The following is a description of a gene set: studied in species Homo sapiens Human Gene Set: GOCC_LATE_ENDOSOME A prelysosomal endocytic organelle differentiated from early endosomes by lower lumenal pH and different protein composition. Late endosomes are more spherical than early endosomes and are mostly juxtanuclear, being concentrated near the microtubule organizing center., and this is the list of marker genes: MVB12B, MREG, OSBPL11, ECPAS, TMEM230, CXCR4, RAB22A, DERL1, RAPGEF2, ADAM30, TPCN2, LAMTOR1, ANXA8, MBL2, VIPAS39, SLC39A14, GRIN2B, MCOLN3, F2R, SLC9A8, TMEM163 (transmembrane protein 163), LAPTM4B, PGA3, ANKRD27, CRHBP, GNPNAT1, MAGI2, UBXN6, ANKRD13B, LGMN, SLC31A2, ATP10B, SFTPD, VPS39, CHMP6, VPS37B, HLA-DOB, RAB27B, ATP13A3, VAC14, NDFIP2, RMC1, ANKRD13A, CHMP1B, MAP1LC3A, LITAF, SLC29A3, AP5Z1, DENND10, MAP2K1, UVRAG, PLD3, SFTPA1, TPT1, VAMP5, SORL1, SFTPC, VPS11, TMEM192, VTI1B, ATP9A, LAMP5, HLA-DRA, MAPKAP1, RAB7A, SLC30A2, SNX14, RNF133, VPS28, B2M, CTSH, PIK3R4, VPS4B, LITAFD, VPS13C, ZMPSTE24, WDR81, VPS37A, HGS, LAMP2, STARD3NL, ASTN2, CD2AP, LRRK2, LAMTOR5, LAMP1, ARL8A, PIP4P2, TF, KCMF1, MTM1, MAPK3, ZC3HAV1, CD79A, FIG4, RNF13 (ring finger protein 13), TSPAN15, CHMP4B, BAIAP3, SLC2A4, VPS37C, HLA-DQB2, NAPSA, PIP4P1, ANXA2, VPS26B, MAP2K2, RASGEF1B, IRGM, NTRK1, RNF149, SIGLEC1, VTA1 (vesicle trafficking 1), SPPL2A, IL12A, CHMP4BP1, MITD1, SLC9A9, NSG1, IFITM3, RNF148, YIPF1, NBR1, WASHC1, ANKRD13D, MARCHF1, IL12B, NPC1, VPS35, CHMP1A, EGFR (epidermal growth factor receptor), SMIM22, CHMP2B, STX7, ABCA5, VAMP8, KCNK6, CHMP4C, RNF128, M6PR, CD1E, IGF2R, IFNAR1, RAB31, HLA-DOA, CD300LG (CD300 molecule like family member g), ANXA6, HDAC6, IFITM2, AP5M1, INSR, VPS8, MFSD12, SMO, NEDD4L, RAB11A, SFTPA2, SLC30A4, SLA2, CD74, ABCB6, SRC, SLC9A6, EXOC8, PIK3C3, TICAM2, UBE2A, CLCN3, BST2, GOSR2, SCARB2, CHMP5, SLC11A2, CST7, HLA-DRB3, PRKAR1A, NMNAT2, MCOLN1, VPS4A, ACP3, ARAP1, NOTCH1, SLC17A8, ATG9A, RILP, DERL2, ABHD6, VPS36, MON1B, ARL8B, GALNTL5, VTI1A, DYSF, GRN, HLA-DRB1, HLA-DMA, VPS37D, DDIT3, PRKAR1B, TMEM106B, VPS29, TMEM59, MARCHF8, HLA-DPA1, TSG101, APOA5, WDR91, RUBCN (rubicon autophagy regulator, NCBI Gene Id 9711), ATP13A5, CHMP3, VPS33A, AP5S1, STEAP3, MON1A, CYB561A3, TMEM30A, HLA-DQA1, BLTP3A, PIKFYVE, HLA-DQA2, KCNQ1, MMD, SLC11A1, OSBPL9, CHMP4A, HLA-DRB4, VOPP1, OSBPL1A, YIPF2, PLD1, STX8, RAP1A, APOE, MICALL1, CD63, SDF4, SLC30A3, VPS16, TCIRG1, LDLR, HTT (NCBI Gene Id 3064), MCOLN2, SFTPB, GFRA1, LAMTOR3, HLA-DQB1, HLA-DRB5, KIDINS220, RAB14, PMEL, VPS33B, ZFYVE26, VAMP7 (NCBI Gene Id 6845), RAB27A, RAB9B, MR1, CHMP2A, DYNC1LI2 (dynein cytoplasmic 1 light intermediate chain 2), SLC31A1, RAB9A, CCZ1, SLC1A1, CHID1, PGA4, AP1AR, GIMAP5, LRAT, CD68, TMEM25, SLC38A9, ATP13A4, NSG2, HLA-DMB, CLEC16A, WDR48, PARM1, VPS41, CCZ1B, BACE1, ATP7B, CTNS, LAMP3, MYO5A, CTSL, RAB7B (NCBI Gene Id 84855), ELAPOR1, SNX16, MVB12A, ENTREP1, TMEM9, CDIP1, ABCA3, MTMR4, ATP13A2, GPR65, VPS18, PGA5, STARD3, CLCN4, ZP2, CTSS, CLTCL1, TTPA, PSAP, SPAAR, MAPK1, PCSK9, HLA-DPB1, CLCN6, RHOB, STOML1, UNC13D, SQSTM1, PLEKHM1, LAPTM4A, LAMTOR2, ATP7A, SNF8, CLN3 (NCBI Gene Id 1201), CHMP7, AP5B1, FYCO1, LAMTOR4